The following is a description of a gene set: Human Gene Set: WP_APOE_AND_MIR146_IN_INFLAMMATION_AND_ATHEROSCLEROSIS studied in species Homo sapiens ApoE and miR-146 in inflammation and atherosclerosis, and this is the list of marker genes: NFKB2, TLR2, SPI1, TRAF6, RELA, APOE, IRAK1, TLR4, MIR146A